Given this list of marker genes ESYT1, ESYT3, VAPA, VAPB, TLE6, POLR2M, ESYT2, GRAMD2A (NCBI Gene Id 196996), ZBED3, here is a description of the gene set: Human Gene Set: GOBP_ENDOPLASMIC_RETICULUM_LOCALIZATION studied in species Homo sapiens Any process in which endoplasmic reticulum is transported to, and/or maintained in, a specific location within the cell.